Given this list of marker genes PLXNA3, PLXNA1, OTP, NDNF, NRP1, HAP1, PRDM13 (PR/SET domain 13), SEMA3E, NRP2, UBB, NHLH2, POU3F2, PROP1, here is a description of the gene set: Human Gene Set: GOBP_HYPOTHALAMUS_CELL_DIFFERENTIATION studied in species Homo sapiens The differentiation of cells that will contribute to the structure and function of the hypothalamus.